The following is a description of a gene set: studied in species Mus musculus Genes negatively differentially expressed in cell type: NK cell upon treatment with cytokine: IL-1β in mouse lymph nodes in vivo. Mouse Gene Set: CUI_NK_CELL_IL1B_RESPONSE_DN Cytokines mediate cell-cell communication in the immune system and represent important therapeutic targets. A myriad of studies have highlighted their central role in immune function, yet we lack a global view of the cellular responses of each immune cell type to each cytokine. To address this gap, the authors created the Immune Dictionary, a compendium of single-cell transcriptomic profiles of more than 17 immune cell types in response to each of 86 cytokines (>1,400 cytokine-cell type combinations) in mouse lymph nodes in vivo. A cytokine-centric view of the dictionary revealed that most cytokines induce highly cell-type-specific responses. For example, the inflammatory cytokine interleukin-1β induces distinct gene programmes in almost every cell type. A cell-type-centric view of the dictionary identified more than 66 cytokine-driven cellular polarization states across immune cell types, including previously uncharacterized states such as an interleukin-18-induced polyfunctional natural killer cell state. from publication Cui A, Huang T, Li S, Ma A, Pérez JL, Sander C, Keskin DB, Wu CJ, Fraenkel E, Hacohen N (PMID 38057668), and this is the list of marker genes: Klrk1, Tmem258, Dnaja1, Vegfc, Ppp1r14b, Jund, Samd9l, Itgb1, Krtcap2, Xcl1, Ptp4a3, Ndufb2, Hsp90ab1, Arhgdib, Hnrnpf, Hnrnpc, Tuba1b, Eno1, Cct3, Prr5l, Mrps15, Sdf2l1, Pfn1, Lrrfip1, Add3, Srsf10, Efhd2, Jun, Irf2bp2, Ahnak, Junb, Hspa1b, Cd9, Atp1b1, Kras, Ddx39a, Fos, Cd28, Crip1, Thy1, Gng5, Ccr5, Hsd11b1, Itgb2, Nme1, Zyx, Psmb8, Gem, Cd48, Arhgef18, Dynll1, Otulin, Cfl1, Vim, Hspa8, Scimp, Fkbp3, Dusp1 (NCBI Gene Id 98098), Ptpn6, Anxa1, Ndufb7, Bin2, Tyrobp, Ndufa2, Fcer1g, Flna, Dnajc2, S100a10, Cd52, Ifng, Ncr1, Pycard, Ms4a4b, Lck, Rhob, Ncor1, H2az1, Anxa6, Lgals1, Chd3, Csnk2a1, Ndufs5, Cxcr3, Btg2, Klf2, H1f2, Nkg7, Ccl3, Foxn3, Pet100, Ctsd, Ndufa4, Zcrb1, Arl4c, Emp3, S100a6, Csk, Gas7, H2aj, Itgb7, Uqcrb, Ptger4, Myl6, Cd160, Calm2, Ccl4, St3gal6, S100a13, Arl4d, Reep5, Tuba1c, Zeb2, Ctsw, Ubxn1